Given this list of marker genes Mark2 (MAP/microtubule affinity regulating kinase 2), Zfp395, Cln6, Med19, Dsc3, Klhl13, Kif1a, Tcfl5, Sppl2a, Naca, Mdga1, Rbmxl2, Septin6 (NCBI Gene Id 80615), Ramp2, Atg9a, Psg21, Dclk1, Adar, Slc43a2, Mink1, Ces2g, Dynlrb1, Crx, Tmem33, Nkx2-1, here is a description of the gene set: studied in species Mus musculus from publication Chen Y, Wang X (PMID 31504780) Mouse Gene Set: MIR_6909_5P Genes predicted to be targets of miRBase v22 microRNA mmu_miR_6909_5p in miRDB v6.0 with MirTarget v4 prediction scores > 80 (high confidence targets).